Given this list of marker genes Cd44, Il12rb2, Cd4, Il11ra2, Il1r1, Ccrl2, Il17rd, Il3ra, Osmr, Prlr, Cx3cr1, Il13ra1, Il20rb, Il31ra, Ccr8, Ccr1, Lepr, Gfra2, Il9r, Gfral, Ccr2 (NCBI Gene Id 235692), Il18rap, Il10ra, Epor, Il22ra1, Il1rap, Lifr, Il12b, Gfra1, Cntfr, Il11ra3, Cxcr2, Il1rl1, Ccr1l1, Il23r, Il2rb, Mpl, Csf2rb, Il17re, Ifnar2, Il22ra2, Cxcr4, Il1rl2, Il6ra, Ifnlr1, Ackr3, Csf3r, Il12rb1, Flt3, Il15ra, Il27ra, Il4ra, Ebi3, Il17rb, Ccr6, Il10rb (interleukin 10 receptor, beta), Cxcr5, Ccr7, Gpr35, Cxcr3, Il20ra, Csf2ra, Il2ra, Gpr75, Gfra4, Il17ra, Il5ra, Il6st, Ifngr2 (interferon gamma receptor 2), Il21r, Ccr4, Xcr1, Ifnar1, Il13ra2, Ccr10, Ccr3, Il2rg, Il1rapl2, Fzd4, Cxcr1, Gfra3, Ghr, Csf2rb2, Cd74, Il11ra1, Ccr5, F3, Crlf1 (cytokine receptor-like factor 1), Il7r, Ackr4, Il18r1, Ackr2 (atypical chemokine receptor 2), Il1r2 (interleukin 1 receptor, type II), Crlf2, Ccr9 (C-C motif chemokine receptor 9), Ifngr1, Cxcr6, Il17rc, here is a description of the gene set: species: Mus musculus Mouse Gene Set: GOMF_CYTOKINE_RECEPTOR_ACTIVITY Combining with a cytokine and transmitting the signal from one side of the membrane to the other to initiate a change in cell activity.